The following is a description of a gene set: studied in species Mus musculus electronically inferred by orthology from the curated human pathway This event has been computationally inferred from an event that has been demonstrated in another species.<p>The inference is based on the homology mapping from PANTHER. Briefly, reactions for which all involved PhysicalEntities (in input, output and catalyst) have a mapped orthologue/paralogue (for complexes at least 75% of components must have a mapping) are inferred to the other species. Reactome Pathway: Glycoprotein hormones part of: Peptide hormone biosynthesis, and this is the list of marker genes: Inhba, Inhbb, Cga, Inhbc, Fshb